The following is a description of a gene set: Mouse Gene Set: GOBP_RESPONSE_TO_OXYGEN_RADICAL Any process that results in a change in state or activity of a cell or an organism (in terms of movement, secretion, enzyme production, gene expression, etc.) as a result of an oxygen radical stimulus. An oxygen radical is any oxygen species that carries a free electron; examples include hydroxyl radicals and the superoxide anion. studied in species Mus musculus, and this is the list of marker genes: Sod3, Cygb, Prdx1 (NCBI Gene Id 18477), Mt3, Dhfr, Parp1, Sod1, Adprs, Ercc6, Prdx2, Mpo, Park7, Sod2, Ucp3, Gch1, Nqo1, Atp7a (NCBI Gene Id 51824), Mb, Fbln5, Ccs (copper chaperone for superoxide dismutase), Nos3, Nfe2l2, Apoa4, Ucp2, Fancc, Cd36, Txnrd2